Given this list of marker genes BC064078, Rragd, Il2rb, Il2ra, Mcub, Kif3b, Il10ra, Map3k8, Sting1, Armcx4, Mcm7, Sypl1, Hipk2, Sord, Foxp3, Elovl6, Zfp608, Tnfrsf4, St14, Gpr83, here is a description of the gene set: FOXP3 target genes up-regulated in T lymphocytes after stimulation with IL2. Mouse Gene Set: GAVIN_IL2_RESPONSIVE_FOXP3_TARGETS_UP Regulatory CD4+ T cells (Tr cells), the development of which is critically dependent on X-linked transcription factor Foxp3 (forkhead box P3), prevent self-destructive immune responses. Despite its important role, molecular and functional features conferred by Foxp3 to Tr precursor cells remain unknown. It has been suggested that Foxp3 expression is required for both survival of Tr precursors as well as their inability to produce interleukin (IL)-2 and independently proliferate after T-cell-receptor engagement, raising the possibility that such 'anergy' and Tr suppressive capacity are intimately linked. Here we show, by dissociating Foxp3-dependent features from those induced by the signals preceding and promoting its expression in mice, that the latter signals include several functional and transcriptional hallmarks of Tr cells. Although its function is required for Tr cell suppressor activity, Foxp3 to a large extent amplifies and fixes pre-established molecular features of Tr cells, including anergy and dependence on paracrine IL-2. Furthermore, Foxp3 solidifies Tr cell lineage stability through modification of cell surface and signalling molecules, resulting in adaptation to the signals required to induce and maintain Tr cells. This adaptation includes Foxp3-dependent repression of cyclic nucleotide phosphodiesterase 3B, affecting genes responsible for Tr cell homeostasis. from publication Gavin MA, Rasmussen JP, Fontenot JD, Vasta V, Manganiello VC, Beavo JA, Rudensky AY (PMID 17220874) studied in species Mus musculus